The following is a description of a gene set: Human Gene Set: GOMF_TASTE_RECEPTOR_ACTIVITY species: Homo sapiens Combining with soluble compounds to initiate a change in cell activity. These receptors are responsible for the sense of taste., and this is the list of marker genes: FFAR4, TAS2R39, TAS2R38, TAS1R2, TAS2R10, TAS2R3, TAS2R1, TAS2R45, TAS1R3, PKD1L3, TAS2R42, TAS2R16, TAS2R60, PKD2L1 (NCBI Gene Id 9033), TAS2R46, TAS2R43 (taste 2 receptor member 43), TAS2R50, TAS2R4, TAS2R5, TAS2R30, TAS2R40, TAS2R19, TAS1R1, TAS2R14, TAS2R9, TAS2R20, TAS2R13, TAS2R41, TAS2R8, TAS2R7, TAS2R31